Given this list of marker genes NCMAP, ABCC6, TULP3, SLC4A10, PTPN5, GNB5, DCDC2, CACNB3, P2RX5, TET2, EIF4E2, KLHL29, METTL6, ATP8B4, MTRF1L, DKC1, PROSER1, SOX6, NFAT5, ATP11B, PPP6R3, ONECUT2 (one cut homeobox 2), FUCA1, MAPK10, PRLR, SYNJ2BP, BUB1B, SMURF2, NCAM1, CTCFL, STXBP5, ANK3, PEAR1, KLF12, MTF2, PLXDC2, SLC35E2B, PCMTD1, BICRAL, MAPRE1, EPHA5, CYTH2, RIMS3, DMP1, CLEC2A, SLC30A4, B4GALT1, RNF166, CARMIL1, HOXB13, RPL7L1, CD300LG, SLC35B3, CD38 (CD38 molecule), PICALM, ANKFY1, ZNF644, CERS6, CBL, C22orf39, DGKH, DUSP5, RBPMS, MAPK1, CCN3, NCOA3, RANBP10, ANXA7 (annexin A7), UBXN4, CISD1, LHX2, ATXN1, KIAA1549, SLC44A1, HCFC2, PHKA1 (phosphorylase kinase regulatory subunit alpha 1), FOXO3, MPI, NPHS2, DST, NR6A1, MAP7, PTBP3, NLRP5, SFXN3, EMC4, EML6, NCOA7, PAM, MDM4, RAB30, MKRN1 (makorin ring finger protein 1), ANKRD44, TESK1, CCDC103, ADRA2A, SUCO, PTPRR, ACSM5, C1orf56, GREB1, RAB2B, GGH, E2F6, MXD1, SEMA3E, ZNF711, FRYL, ZC3H7A, TMEM192, NXPH1, CYP3A5, BTBD9, ADCY1, ELMO1, CAPN7, SH3D19, SENP5, KLHL34, GPD2, OTX2, UGCG, PLEKHA5, SIAH3, FAM241B, ZNF302, KCNMB2, ZNF704, KEL, FNDC5, MSTN, KCNRG, WFDC1, SRSF8, FGFR2, FCHSD2, USP24, DENND1B, ATCAY, MAPK4, ICE1, PKN2, MECP2, TTN, PTCHD4, CREBRF, SLC35E2A, IGLL1, RNMT, SEMA3A, FRMD4B, CIPC, AMBN, CACUL1, here is a description of the gene set: Genes predicted to be targets of miRBase v22 microRNA hsa-miR-5691, hsa-miR-6805-3p in miRDB v6.0 with MirTarget v4 prediction scores > 80 (high confidence targets). from publication Chen Y, Wang X (PMID 31504780) Human Gene Set: MIR5691_MIR6805_3P studied in species Homo sapiens